Given this list of marker genes Tnf, Xbp1, Vegfb, Slc12a2, Smoc2, Foxc2, Tafa5, Alox5, Cxcr4, Hif1a, Serpine1 (NCBI Gene Id 231790), here is a description of the gene set: studied in species Mus musculus Any process that modulates the rate, frequency, or extent of blood vessel formation when new vessels emerge from the proliferation of pre-existing blood vessels and contribute to the series of events that restore integrity to damaged vasculature. Mouse Gene Set: GOBP_REGULATION_OF_VASCULAR_WOUND_HEALING